The following is a description of a gene set: Mouse Gene Set: GOBP_REGULATION_OF_RESPONSE_TO_OSMOTIC_STRESS studied in species Mus musculus Any process that modulates the rate or extent of the response to osmotic stress., and this is the list of marker genes: Ryr1, Micu1, Epo, Bdkrb2, Ybx3, Efhd1, Slc25a23, Gypa, Tifab, Abcb1b, Usp15, Abcb1a, Bad, Letm1, Mlc1, Cln3, Trpv4, Ptgs2